Given this list of marker genes Mus81, Polk, Pold2, Pole, Rfc4 (NCBI Gene Id 224052), Xrcc3, Brip1, Rfc1, Rpa2, Rmi2, Rbbp8, Rps27a, Ubb, Eme1, Dna2, Rad51c, Rad51d, Xrcc2, Uba52, Spidr, Polh, Rad51ap1, Rad51, Rpa3, Rad50, Pole4, Pcna, Wrn, Nbn, Eme2, Rfc3, Firrm, Kat5, Slx1b, Gen1, Mre11a, Palb2, Rfc2, Uba52rt, Rfc5, Pole3, Chek1, Blm, Pole2 (polymerase (DNA directed), epsilon 2 (p59 subunit)), Pold1, Brca1, Brca2, Exo1, Top3a, Bard1, Ubc, Pold4, Rmi1, Rad51b, Slx4, Rpa1, Atm, Pold3, Fignl1, here is a description of the gene set: HDR through Homologous Recombination (HRR) studied in species Mus musculus Mouse Gene Set: REACTOME_HDR_THROUGH_HOMOLOGOUS_RECOMBINATION_HRR